The following is a description of a gene set: species: Homo sapiens Pancreatitis The presence of inflammation in the pancreas. Human Gene Set: HP_PANCREATITIS, and this is the list of marker genes: MT-TH, NDUFS3, LPL, MT-ND5, MMUT, CTLA4, SLC7A7, LMF1, MT-TQ, MT-CO2, CAV1, ALMS1 (ALMS1 centrosome and basal body associated protein), PPARG, TLR4, ERAP1, CPA1, HMGCL, CYBC1, MPV17, STUB1, NSMCE2, BSCL2, SLC25A13, ATP7B, PTPN22, HLA-DPB1, IKZF1, SMARCAL1, HLA-DPA1, RNU7-1, GCGR, STAT4, CIDEC, BCKDHA, MT-TF, ATP8B1, FAS, UBAC2, XPNPEP3, GPR35, SPINK1, UQCRH, MT-ND4, CTRC, MT-CO1, C4A, APOE, MT-CO3, G6PC1, LMNA, FLI1, ASL, MT-ND1, PNPLA2, CDC73, AIRE, TKFC, PRSS2, PRTN3, CRELD1, GK, IL12A, PRSS1, ESAM, MT-TL1, GNA11, GPIHBP1, IFNGR1, IFT172, TCF4, MT-ND6, AGPAT2, ABCB4, MEFV, KLRC4, PCCA, CASR, TRPV6, GNAS, TGFB1, FCGR2A, HLA-B, SEMA4D, IL10 (interleukin 10), MT-TW, IVD, NADK2, APOC2, PCCB, IL12A-AS1, IL23R, CBS, CCDC47, CFTR, NFS1, SLC37A4, MST1, AP2S1, PDE11A, ACTG2, CCR1, MT-TS2